The following is a description of a gene set: from publication Tesar PJ, Chenoweth JG, Brook FA, Davies TJ, Evans EP, Mack DL, Gardner RL, McKay RD (PMID 17597760) Genes up-regulated in hES cells (human embryonic stem cells) after treatment with the ALK inhibitor SB-431542. species: Homo sapiens The application of human embryonic stem (ES) cells in medicine and biology has an inherent reliance on understanding the starting cell population. Human ES cells differ from mouse ES cells and the specific embryonic origin of both cell types is unclear. Previous work suggested that mouse ES cells could only be obtained from the embryo before implantation in the uterus. Here we show that cell lines can be derived from the epiblast, a tissue of the post-implantation embryo that generates the embryo proper. These cells, which we refer to as EpiSCs (post-implantation epiblast-derived stem cells), express transcription factors known to regulate pluripotency, maintain their genomic integrity, and robustly differentiate into the major somatic cell types as well as primordial germ cells. The EpiSC lines are distinct from mouse ES cells in their epigenetic state and the signals controlling their differentiation. Furthermore, EpiSC and human ES cells share patterns of gene expression and signalling responses that normally function in the epiblast. These results show that epiblast cells can be maintained as stable cell lines and interrogated to understand how pluripotent cells generate distinct fates during early development. Human Gene Set: TESAR_ALK_TARGETS_HUMAN_ES_5D_UP, and this is the list of marker genes: SOX1, PAX6, GBX2, MSX1, ZIC1